Given this list of marker genes Bccip, Fgfr3, Tubb5, Cebpb, Sox11, Nkx2-2, Afdn, Rfx6, Ctnnb1, Otp, Ipo7, Lhx3 (NCBI Gene Id 16871), Smad2, Emx1, Wnt11, Fgf2, Ascl1 (NCBI Gene Id 17172), Fgf8, Abl2 (ABL proto-oncogene 2, non-receptor tyrosine kinase), Dll1, Tmem231, Vax1, Rptor, Notch1, B9d1, Nkx6-3, Insm1, Ift80, Gata2, Dspp, Dlg5, Onecut1, Gak, Serpine1, Cdh2, Tgfb1, Dlx3, Msx1, Mir875, Nfe2l1, Nodal, Fam20c, Pou3f2, Hes1, Map1b, Abl1, Lef1, Kdm2a, Bmp4 (bone morphogenetic protein 4), Jag1, Sox4, Otx2, Wnt4, Bmp2, here is a description of the gene set: The process in which epiblast cells acquire specialized features of neuroepithelial cells. studied in species Mus musculus Mouse Gene Set: GOBP_NEUROEPITHELIAL_CELL_DIFFERENTIATION